Given this list of marker genes ANKS4B, CDHR2, CALML4, USH1C, TMIGD1, MYO7B, CDHR5, here is a description of the gene set: The aggregation, arrangement and bonding together of adjacent microvilli through the formation of Ca(2+)-dependent adhesion links between them, forming a brush border. studied in species Homo sapiens Human Gene Set: GOBP_BRUSH_BORDER_ASSEMBLY